Given this list of marker genes PTPRM, UNC119, SLC6A18, PSD2, ETFBKMT, CDK17, PAPPA2, ALDH1A2, CPA3, CTSS (cathepsin S), TNFRSF25, TNKS1BP1, NR1D1, MMP9, BPNT2, NAA25, SLC28A3, PSD4, BLK, TPTE, MUC4, THEM6, GPR6, TOMM40L, PRR13, NPY1R, CHAD, HLA-B, ALDOAP2, TNFRSF21, ADAMTSL3 (ADAMTS like 3), F2R, DIPK2A, HDAC6, EDIL3, TNK2, SAR1B, ZNF580, EGFLAM, FURIN, ABI3BP, PUS1, DDIT3, PRODH2, DLG1, MAN1C1, CDH16, UBE2U, TFEB, GSTA3, NRP1 (neuropilin 1), EPS8L3, CLEC5A, PLPPR1, CDC25A, PPM1K, C1orf52, TNFSF14, MRPL46, IFI35, RTP4, SLC5A7, ICOS, PRAM1, CHD6, DKK3, PLEKHG1, B3GNT7, STOX1, PTPRZ1, PCDH7, RFXANK, CERS4, JAG1, NWD1, CCR6, COPRS, FOSL2, TTLL8, WDFY3, CLTB, SLC23A2, TDRD7, FGL2, SCARA3, MTCL3, CCND3, TDRD9, PDE5A, SIX3, MCF2, CMTM2, SASH1, DSP, SLC11A2, SOX2-OT, CST11, SLC4A4, SERTAD1, DNAH12, ZFYVE28, CEBPZOS, RFXAP, NOTCH4, FCER1G, GBP6, PRL (prolactin), BICD1, IFITM3, CMTM6, GZMB (granzyme B), IDNK, ASCC3, PLGRKT, RFTN1, TSPO2, REG3G, IL7R, ADAR, LRRTM2, GANAB, C5AR1, RNF207, PLIN4, SLURP1, ATP12A, TRIML1, CBS, CXCR6, POSTN, KRT76, SPACA9, MGAT4A, PHC1, SRPX, TOX2, TMEM140, UCK2, SCIN, RBPMS2, CPEB2, TMEM64, TGFBR1, ZBTB3, SLF2, STAB2, VCPIP1, CFAP119, CXCR5, MAF, LTB4R, HEY1, FERMT2, ZBTB39, WDR43, GRB10, KPRP, TMEM61, FBXO31, MYNN, SDC4, MOSMO (NCBI Gene Id 730593), RNASE4, FAM163A, PLAC8L1, DCDC2B, HS3ST3B1, RORC, OSBPL3, CFI, PLEKHF1, KPNA7, ITGA10, ACTN2, TRPM2, SUSD2, PHLDA1, AAK1, ZDHHC11, DACH1, UPP1, RINL, FOXP3, CISH, FFAR4, FPR3, KCNK1, APLF, TNP1, IL22, RBL2, NGRN, ID2, JADE2 (NCBI Gene Id 23338), CPD, TMC4, PDE6B, HGD, NAT10, here is a description of the gene set: Genes up-regulated in comparison of TCF7 deficient early thymic progenitors versus the TCF7 sufficient ones. Although transcriptional programs associated with T-cell specification and commitment have been described, the functional hierarchy and the roles of key regulators in structuring/ orchestrating these programs remain unclear. Activation of Notch signaling in uncommitted precursors by the thymic stroma initiates the T-cell differentiation program. One regulator first induced in these precursors is the DNA binding protein Tcf-1, a T-cell specific mediator of Wnt signaling. Yet the specific contribution of Tcf-1 to early T-cell development and the signals inducing it in these cells remain unclear. Here we assign functional significance to Tcf-1 as a gatekeeper of T-cell fate. We show that Tcf-1 is directly activated by Notch signals. Tcf-1 is required at the earliest phase of Tcell determination for progression beyond the early thymic progenitor (ETP) stage. The global expression profile of Tcf-1 deficient progenitors indicates that basic processes of DNA metabolism are downregulated in its absence and the blocked T-cell progenitors become abortive and die by apoptosis. Our data thus add an important functional relationship to the roadmap of T-cell development. We used microarrays to detail the global programme of gene expression of mouse ETP thymocyte after Ikaros inactivation with dominant negative of Ik at different stage. Human Gene Set: GSE33513_TCF7_KO_VS_HET_EARLY_THYMIC_PROGENITOR_UP from publication Germar K, Dose M, Konstantinou T, Zhang J, Wang H, Lobry C, Arnett KL, Blacklow SC, Aifantis I, Aster JC, Gounari F (PMID 22109558) studied in species Homo sapiens